Given this list of marker genes LTBR, SEMA3C, CASP1, MMP14, APCS, HBEGF, ACTN3, EDN3, BST1, ASGR1, SERPINB8, CHRNB4, CD1C, DUSP2 (dual specificity phosphatase 2), PDXK, here is a description of the gene set: Genes in the cancer module 501. species: Homo sapiens Human Gene Set: MODULE_501